Given this list of marker genes DDX3X, MPV17L2, TRUB2, UQCC2, NGRN, MIURF, RCC1L, C1QBP, RPUSD3, FASTKD3, TRMT10C, COA3, FASTKD2, RPUSD4 (NCBI Gene Id 84881), CDK5RAP1, RMND1, METTL8, here is a description of the gene set: Human Gene Set: GOBP_POSITIVE_REGULATION_OF_MITOCHONDRIAL_TRANSLATION species: Homo sapiens Any process that activates or increases the frequency, rate or extent of the chemical reactions and pathways resulting in the formation of proteins by the translation of mRNA in a mitochondrion.